Given this list of marker genes Slc33a1, Zfp36l1, Nup42, Slc25a4, Nup85, Alyreffm5, Thoc7 (NCBI Gene Id 66231), Alyreffm4, Nup214, Nxt1, Lrrc8a, Ncbp2 (NCBI Gene Id 98015), Sec13, Hhex, Slc29a4, Slc35b3, Nup58, Slc25a5, Calhm6, Pom121l2, Lrrc8e, Peg10, Slc25a51, Slc25a19, Cetn2, Aaas, Ythdc1, Slc28a3, Slc25a17, Kpnb1, Khsrp, Tnks, Rftn1, Alyreffm3, Eif4a3, Lrrc8c, Adcy10, Slc29a1, Ncbp1, Mapt, Tomm20, Srsf3, Chtop, Poldip3, Nup160, Alyreffm9, Slc25a41, Ckap5, Pabpn1, Senp2, Rftn2, Xpo5, Nup62, Nup153, Hsf1, Fxr1, Sem1, Alyreffm6, Eif4e, Slc35c2, Nxt2, Fxr2, Alyref2, Slc25a42, Wnk1, Thoc5, Fmr1, Igf2bp1, Thoc6, Nxf1, Thoc1, 1700017N19Rik, Calhm4, Abcc1, Nup88, Nxf2, Akap8l, Abcc6, Alyreffm14, Alyreffm7, Fyttd1, Slc35b4, Zc3h11a, Tst, Gjb1, Cd47, Calhm3, Cpsf6, Shoc2, Alyreffm2, Seh1l, Magohb, Slc28a2b, Alyreffm1, Gle1, Rae1, Nup62cl, Nup98, Ddx39a, Hnrnpa1, Cpeb1, Slc17a9, Qki, Igf2bp3, Slc25a54, Xpot, Ran, Snupn, Nup54, Nup210, Ddx19b, Abcc5, Sarnp, Pcid2, Parp11, G3bp2, Nup107 (NCBI Gene Id 97632), Ahctf1, Slc35d1, Magoh, Tgfbr2 (transforming growth factor, beta receptor II), Ndc1, Slc25a24, Epg5 (NCBI Gene Id 71423), Slc25a47, Gja1, Abcc4, Slc35b1, Slc25a25, P2rx7, Nup37, Nup155 (NCBI Gene Id 170762), Panx1, Slc25a26, Slc19a1, Nup50, Zfp36, Casc3, Adora1, Slc25a16, Srsf1, Mrpl18, Nxf7, Mcm3ap, Arc, Hnrnpa2b1, Eny2, Tpr, Nup188, Abcd1, Slc25a36, Ssb, Srsf7 (NCBI Gene Id 60426), Thoc2, Alkbh5, Ncbp3, Igf2bp2, Calhm5, Ripk1, Ddx39b, Flot1, Slc35a5, Zc3h3, Pom121 (nuclear pore membrane protein 121), Calhm1, Slc46a2, Tmem241, Thoc2l, Xpo1, Phax (phosphorylated adaptor for RNA export), Lrrc8b, Thoc3, Nutf2, Khdrbs1, Alyreffm11, Alyreffm8, Slc25a23, Calhm2, Slc28a2, Nup35, Slc35d3, Supt6 (SPT6, histone chaperone and transcription elongation factor), Ank, Nol6, Bicd2, Setd2, Alyreffm10, Lrrc8d, Slc25a33, Nup133, Dhx9, Htt, Nsun2, Tomm20l, Slc28a1, Rbm15b, Lrpprc, Ddx19a (DEAD box helicase 19a), Nup93, Cetn3, Iws1, Sidt1, Slc35b2, Alyref (NCBI Gene Id 21681), Ranbp2, Nxf3, Slc25a31, Nrde2, Hnrnpa3, Ybx1, Slc35d2, Slc29a2, Pnpt1, Ddx25, Kif5c, Slc35a3, Slc35a2, Slbp, Rbm33, Slc35c1, Slc35a1 (solute carrier family 35 (CMP-sialic acid transporter), member 1), Nup43, Ranbp17, Slc25a32, Slc29a3, Sidt2, Rbm8a, here is a description of the gene set: studied in species Mus musculus The directed movement of nucleobases, nucleosides, nucleotides and nucleic acids, into, out of or within a cell, or between cells, by means of some agent such as a transporter or pore. Mouse Gene Set: GOBP_NUCLEOBASE_CONTAINING_COMPOUND_TRANSPORT